Given this list of marker genes CRKL, LAMA2, GGA3 (NCBI Gene Id 23163), SH3GL2, UBC, CBL, COL1A2, MET, COL3A1, TNS3, HGF, LAMA3, PIK3R1, SH3GL1, LRIG1 (NCBI Gene Id 26018), COL5A1, EPS15, PIK3CA, LAMB1 (laminin subunit beta 1), ITGA2, LAMC3, COL5A3, STAM2, SRC, LAMA1, PTK2, PTPN1, DOCK7, HGS, SHC1, MUC20, COL11A1, RAB4A, SH3KBP1, COL27A1, LAMA4, COL1A1, PTPN2, UBA52, USP8, NRAS, FN1, LAMC2, RAP1A, RAC1 (NCBI Gene Id 5879), ITGB1, LAMA5, RAPGEF1, HRAS, COL5A2, TNS4, SPINT2, PTPN11, CRK, STAM, STAT3, SOS1, COL11A2, RANBP9, UBB, KRAS, COL24A1, LAMB2, RAP1B, GAB1, RPS27A, RANBP10, LAMB3, LAMC1, PTPRJ, HPN, GRB2, ITGA3, RAB4B, SPINT1, ARF6, COL2A1, HGFAC (HGF activator), SH3GL3, here is a description of the gene set: Human Gene Set: REACTOME_SIGNALING_BY_MET Signaling by MET species: Homo sapiens